The following is a description of a gene set: species: Mus musculus Any process that activates or increases the frequency, rate or extent of synaptic transmission, the process of communication from a neuron to a target (neuron, muscle, or secretory cell) across a synapse. Mouse Gene Set: GOBP_POSITIVE_REGULATION_OF_SYNAPTIC_TRANSMISSION, and this is the list of marker genes: Mir1983 (NCBI Gene Id 100316716), Mir467a-1, Slitrk4, Mirlet7c-1, Zdhhc3, Cacng3, Grin2c, Prkce, Cacng2, Syde1, Mir24-1, Mir124a-1hg, Stx4a, Grik2, Mecp2, Shank2, Pten, Mir28a, Mir467a-5, Cyp46a1, Crhr1, Mir328, Mir181a-1, Kiss1r, Mir381, Mir9-1, Mir101a, Nrxn1, Cc2d1a, Htr7, Cacng5, Mir129-1, Rab3gap1, Kiss1, Mir539, Erbb4 (NCBI Gene Id 13869), Slc24a2 (NCBI Gene Id 76376), Egfr, Mir7b, Mir425, Nos1, Gria3 (glutamate receptor, ionotropic, AMPA3 (alpha 3)), Tnr, Akap5, Snca, Hmgcr, Sphk1, Mir673, Car7, Itpr3, Mir130a, Mir330, Stx3, Mir369, Fxr1, Mir195a, Mir382, Mirlet7c-2, Prkcg (NCBI Gene Id 18752), Mir125b-1, Mir17 (NCBI Gene Id 723905), Mir667, Bglap2, Fmr1, Rapsn, Mir467b, Mir181b-1, Mir324, Syt12, Tac1, Mir672, Cacng4, Clstn1, Mir218-1, S100b, Mir337, Adcy8, Mir338, Mir124-2hg, Nalcn, Slc1a1, Gip, Mir30c-1, 2510002D24Rik, Iqsec2, Ncstn, Kmo, Retn, Ephb2, Arrb2, Mir150, Mir551b, Pde9a, Pirb, Kctd13, Crh, Ptpn5, Mir187, Mir467a-4 (microRNA 467a-4), Nmu, Mir540, Dnm1l, Flot1, Mir486, Mir29b-1, Drd2, Shisa7 (shisa family member 7), Mir26a-2, Mir301b, Nps, Mir467a-8, Mir148b, Mir15a (microRNA 15a, NCBI Gene Id 387174), Mir211, Mir145a, Htr6, Glul, Mir378a, Adrb1, Tacr1, Mir29a, Chrnb2, Ncs1, Mir19a, Mir181b-2, Cacng8, Apoe, Mapk1, Mir30d, Ptk2b, Mir151, App, Nfatc4, Slc7a10, Gria2, Mir134, Adora1, Clstn3, Mir191, Uts2, Mirlet7f-2, Mir128-2, Mir19b-2, Ngfr (NCBI Gene Id 18053), Tyrobp, Mir770, Hap1, Chrna7, Mir204, Prnp, Grin1, Hnrnpk, Slc8a2, Mir433, Mir374b (microRNA 374b), Musk, Tnf, Camk2b, Plk2, Ptn, Ptk2 (NCBI Gene Id 14083), Gper1, Igsf11, Mir501, Vamp2, Mir99a, Mpp2, Mir181a-2, Prkar1b, Snap25, Mir222, Mir300, Mirlet7f-1, Mir23b, Lama2, Braf, Grin2b, Htr2c, Drd1, Mir500, Pink1, Gfap, Mir467a-10, Mir20a, Shank3, Prrt1, Mir467a-7, Mir384, Mir9-2, Nlgn1, Mir132, Serpine2, Mir92b, Unc13a, Mir106b, Epha4, Nsg1, Mirlet7d, Mir744, Slc18a3, Ntrk2, Grin2a, Arc, Cacng7, Mir153, Psen1, Ptgs2, Oxtr, Mir674 (NCBI Gene Id 732489), Lgmn, Mir484, Cpeb3, Ckap5, Mir652, Large1, Mir467a-2, Mir127, Mir129-2 (microRNA 129-2), Nptn, Mir218-2, Nf1, Mir30e, Mir23a, Mir421, Mir98 (NCBI Gene Id 723947), Creb1, Mir149, Nog, Ptger4 (prostaglandin E receptor 4 (subtype EP4)), Ccl2, Adcy1, Mir467a-3, Mir93 (microRNA 93), Lrrtm1, Slc4a8, Enpp1, Mir181c, Snap47, Tshz3, Mir434, Kif5b, Gria1, Prkcz, Mir126a, Mir26a-1, Bcl2l1, Grin2d, Nr2e1, Stx1b, Slc1a3, Gpr158, Mir30c-2, Mir467a-9, Dbi, Mir487b, Reln, Bglap, Mir125b-2, Mir760, Cacna1b, Mir128-1, Mir30a, Ythdf1, Mir22, Nlgn2, Ppp1r9a, Nlgn3, Stau1, Rgs14, Cx3cr1, Mir137, Mir320, Mir25, Mir383, Mir7-1, Mir541, Mir9-3, Mir345, Mir411, Crhr2, Fam107a, Ccr2, Oxt, Adra1a, Mme, Mir138-1, Ifng, Slc8a3, Mir872, Mirlet7e, Syt1, Cacna1d, Mirlet7i, Zdhhc12, Mir125a, Mir181d, Adora2a, Mir221, Chrd, Eif2ak4, Abl1, Mir19b-1, Cckbr, Mir26b, Crtc1, Stx1a, Gria4, Mir467a-6, Rims1, Mir410, Sqstm1, Micu3, Mir100, Mir101b, Mir24-2, Adcyap1, Mir342, Slc24a1, Rasgrf2, Zdhhc2, Stxbp1, Clstn2, Efnb3, Mir106a, Ager, Mir138-2, Gsk3b, Ror2, Paip2, Mir7-2, Lrrtm2, Mir30b (NCBI Gene Id 387226), Dlg4 (NCBI Gene Id 13385), Tacr2 (NCBI Gene Id 21337), Rab3a, Ntrk1, Mir92-1, Car2, Baiap3, Mir29b-2, Hdac6, Dtnbp1, Lgi1, Mir379, Grik1 (glutamate receptor, ionotropic, kainate 1), Pak1, Mir92-2, Nrgn